Given this list of marker genes RHOB (NCBI Gene Id 388), PIK3R2, RHOA, PIK3R3, PIK3CA, PIK3R6, LCP2, LYN (LYN proto-oncogene, Src family tyrosine kinase), VAV1, LAT, FCER1G, RAC2, COL1A2, RAC1 (Rac family small GTPase 1), PIK3CB, PIK3R1, LCK, MPIG6B, VAV2, GP6, FYN, PDPN, SYK, CLEC1B, PIK3R5, PTPN6, PDPK1 (3-phosphoinositide dependent protein kinase 1), VAV3, PTPN11, PIK3CG, RHOG, CDC42, PRKCZ, PLCG2, COL1A1, here is a description of the gene set: GPVI-mediated activation cascade studied in species Homo sapiens Human Gene Set: REACTOME_GPVI_MEDIATED_ACTIVATION_CASCADE